The following is a description of a gene set: Mouse Gene Set: GOBP_MINERALOCORTICOID_METABOLIC_PROCESS The chemical reactions and pathways involving mineralocorticoids, hormonal C21 corticosteroids synthesized from cholesterol. Mineralocorticoids act primarily on water and electrolyte balance. species: Mus musculus, and this is the list of marker genes: Clcn2, Ednrb, Bmp5 (bone morphogenetic protein 5), Wnt4, Cyp11b2, Scnn1b, Rest, Dab2, Bmp2 (bone morphogenetic protein 2), Kcnma1, Cyp11b1, Hsd11b1, Dkk3, Bmp6, Cacna1h, Cyp21a1